The following is a description of a gene set: species: Homo sapiens Human Gene Set: GOBP_REGULATION_OF_SYSTEM_PROCESS Any process that modulates the frequency, rate or extent of a system process, a multicellular organismal process carried out by any of the organs or tissues in an organ system., and this is the list of marker genes: LMCD1, SMAD4, TMIGD3, CALM3, MTPN, CRHR1, GSTM2, CARTPT, NPVF, FOXO3, FMR1, MYL3, CASQ1, TRPV4, GDF9, CACNA1G, CTDP1, MIR214, CAMK2G, NR1H2, JPH3, HRC (NCBI Gene Id 3270), MIR133A1 (microRNA 133a-1), PARD3, EIF2AK3, INHA, PRKCA, EDNRB, MIR145, DOCK4, TBX18, SRF, WASF3, APELA, CACNA1C, MYBPH, SLC22A5, NPNT, ATP1B1, CACNA1D, GLRA1, SREBF1, KCNE4, PIRT, CHRM2, MYRF, FAAH, FBXO32, MIR17HG, ENPP7, MIR143, FGF13 (NCBI Gene Id 730528), RNF10, TNFRSF21, DAG1, CTNNA3, RELN, SPP1, CLDN15, ITGA4, TBXAS1, GSTO1, ADRA1A, PAK1, ACTN3 (NCBI Gene Id 89), HCN3, GRIN2A, ATPSCKMT, CDK18, ATP2B3, SRI, JAM2, PPP1R12B, DMPK, DAB2, TMEM100, MTMR2, HDAC4, TNNI3K, SGK1, FGF10, NPSR1, ATP1A3, KCNMB4, RHOA, ITGA9, EPAS1, IGFBP5, DMD, CORO2B, EDN2, BAIAP2, MSTN, CLDN2, YY1, KCNJ5, KIT, TNNC2, THRA, ADCY10, FOXL2, EIF4A3, SUMO1, EMP2, MYOG, ADGRD1, AVPR1A, TWF1, BMP10, MIR30B, MIR499A, MYL9, DOCK5 (dedicator of cytokinesis 5), APOA4, BDKRB2, KCND3, NEUROG1, WNK3, PRKG1, PPP3CA, CD38, INPP5K, HSPB7, S1PR2, ARHGAP42, SMR3A, MAPK8IP2, TLX3, CAV1, BMPR2, MYBPC3, ABCC9, GUCY1A1, SLC8A2, NRXN1, GRIN2C, SLN, UNC13B, TRPA1, MIR19B1, DVL1, MIR26A1, ABCG8, KCNA5, SHOX2, TTR, GNAO1, NLGN4X, LPIN1, INHBA, CYBA, ADM, CAMK2B, CCL3, STX1B, NRDC, DSC2, KCNJ2, JPH1, MIR34B, AGTR1, BMP6, GLRX3, GATA4, ARRB2, GJC1, AKAP6, DSG2, ADORA3, CRY1, SSH1, CHRNA3, NOL3, FKBP1B, MIR208B, TACR3, IRX3, FOXP1, STUB1, DCANP1, IRX5, TNFRSF1B, NOS3, GATA5, HIP1R, PI16 (NCBI Gene Id 221476), CTSC, SCN3B (NCBI Gene Id 55800), WNT7A, ABCG5 (ATP binding cassette subfamily G member 5), CORIN, CYP19A1, AVPR2, AVPR1B, NPPA, CALCA, GAA, RGS2, SETD3, APOA2, ECRG4, EDNRA, TGFB2, SOD1, RIMS1 (regulating synaptic membrane exocytosis 1), MIR34C, HRH2 (histamine receptor H2), EGR2, CHRM3, GJA1, TMEM25, PRKN, RNF207, SOX10, PROK2, ZC3H12A, EPB41, TNF, SLC8A3, OPRPN, CERS1, RETN, TRIM63, HAMP, TPPP, GRM1, MIR92A1, PDE4D, STK39, ADM5, TSPO, TACR1 (tachykinin receptor 1), HTR2C, KBTBD13, GJA5, KCNJ12, TNR, ADA, PTPN11, C1QTNF1, SLC9A1, PDE4B, NLGN2, S100A1, PBX3, CCN3, CALM1, CRH, PHOX2B, KCNIP1, AKAP9, JPH4, MYL4, EHD3, F2R, EDN3, NPR1, TNNI3, SPX, ACE2 (NCBI Gene Id 59272), JPH2, CUX2, SLC1A1, WNK1, MDM2, QKI (QKI, KH domain containing RNA binding), TNNI1, MYL5, FLNA, MIR20A, ADRB1, CYP8B1, BVES, PER2, ITGA2, GPR171, CRHBP, GJD3, MYLK2, NTSR1, FGF12, ABAT, PPARG, DBH, CLIC2, ADRA1B, GPD1L, CHRNA2, TRPM4, DLG4, NETO1, MIR200C, WNK4, KCNJ3, PDE9A, ZFHX2, KCNE2, FXYD1, GRIN2B, GHSR (NCBI Gene Id 92434), KDM5B, FABP5, TIFAB, ATP2A1, CHGA, MYH7, TBX2, POMC, NEUROD1 (NCBI Gene Id 7853), TRPC1, AGT, NPPB, PARP1, PTGER3, MIR17, TMEM38B (transmembrane protein 38B), PTEN, PLN, GJC3, ASIC2, ROCK2, APOA1, FGFR1, F2RL1, KCND2 (potassium voltage-gated channel subfamily D member 2), RGS4 (NCBI Gene Id 5999), DICER1, GSK3A, APLNR, CST7, ANK2, CHRNB4, KCNE5, TYMP, AGER, SCT, SRC (SRC proto-oncogene, non-receptor tyrosine kinase), NOTCH1, G6PD, HCN4, PRAP1, REM1, ADRB2, PTK2B, OXTR, DAPK3, APOE (apolipoprotein E), P2RX1, MIR19A, TMEM38A, ECE1, MTNR1B, HTR1A, NR1H3, MTG1, MIR208A, BIN1, PKP2, TBXA2R, ADORA2B, KCNQ1, TRPC3, MYH6, RIMS2, MGLL, ITGB1, ADRA2B, SVEP1, TNNT3, ERRFI1, CSRP3, DRD2, SMAD7, MIR328, PRKD1, ADD3, NCMAP, POPDC2, ZDHHC21, CC2D1A (NCBI Gene Id 54862), GRIA1, KLF4, CAMK2D, SELENON, ISL1, OXT, ADM2, RANGRF, CBLN1, SNTA1, FOXN4, ACE, PIK3CG, TAFA4, PRKAR1B, TNNT2, NUP155, FIG4, KCNE1, MYL2 (NCBI Gene Id 4633), ADIPOQ, GTF2IRD1, APP, MEF2A, AVP (arginine vasopressin), CXADR, HRH1, REN, SCN4B, HBEGF, MMP2, ADORA1, ABCC8, NHERF1, TNNC1, GAS6, GPER1, MIR199B, ENO1, NPY2R, ANXA6, SMTNL1, IRAG1, KCNJ8, KCNIP2, MIR199A1, HAND2, MIR1-1, TSHZ3, DLG1, ATP2B2, KCNB2, CELF2, ORMDL3, HOPX, FGB, GAL, TPM1, NKX2-5, SMR3B, ARRB1, BECN1, PTPRO, HTR2A (5-hydroxytryptamine receptor 2A), NR4A3, CYP2J2, NOS1AP, P2RX4, GRIK2, TH, RNLS, SHANK1, TENM4, TFF2, MIR25, ABCB1, DSP, IL6ST, SMAD3, KCNH2, TNNT1, CASQ2, SCN10A, SLC4A3, MC3R, FKBP1A, APLN, RYR2, KCNK9, LEP, GRIN1, FOXO1, IGF1, HSP90AA1, CASR, CACNA1S, CRY2, SPTBN4 (NCBI Gene Id 80322), ATP2A2, PARP2, NMU, GLS, CAV3, TMEM65, SLC8A1, NLGN1, UCN, PPARA, ADRA2A, STRIT1, MAG, THRB, ABL1, GHRL, OR51E2, NMUR2, ATP1A1, AGTR2, ATP2A3, ACP3, ZMPSTE24, MTG2, ASPH, SPHK1, TMEM98, GCH1, NEGR1, C12orf57, CACNA2D1, GALR1, KCNH6, FGG, TBX5, CACNB2, PRKCZ, MYH7B, KCNA1, SHANK3, ZNF488, MIR21, LMNA, SCN2B, CACNG1, INHBB, HCN1, STC1, NLGN3, HCRT, TMEM108, KCNMB2, LPCAT3, EDN1, GLP1R, ATP1B2, PRKACA, OPRK1, SCN1B, CTTN, MAP2K1, MYOCD, ACACB, S100B, ADRA2C, TRDN, KCNE3, CNN1, GRIN2D, FGA, LRRK2, RAB8B, TOMM70, STX1A, ATP2B1, MYMK, ATP1A2, PDGFB, CALM2, MLIP, ROCK1, ATP2B4, SCN5A, TBC1D24, FTO, TAC4, CELF4, JUP, GBA1, NKX3-1, AQP1, YWHAE, CHRNA7, GSX2, CACNA1H, TAC1 (tachykinin precursor 1), TMEM161B, NOS1, NPFF, ADRA1D, SCN4A, MIR30E, DES, MECP2, CACNB1, GRK2, HEY2, PTPN1, PRKAG3, KCNN2 (NCBI Gene Id 3781), MIR153-1, ZMYND8, TNFRSF1A, ITGAX, MIR448, TACR2